Given this list of marker genes CLU, IL32, KRT81, LEF1, PANK4, EPB41, NPAS2, HTR2C, DUSP1, XPO7, HBE1, PSME3IP1, PRR16, METTL25B, SBNO1, TMEM101, PPME1, SH3TC2 (NCBI Gene Id 79628), CCL26, MPP1, STX2, MYO10, PRR29, WNT7A, CLDN4, TCIM, EML2, SOX4, IL1B, BCKDHB, ANAPC5, LINC01963, RABEP1, ASTN1, TCF7L2, DVL1, TCF4, SLC16A1, C4orf19, GCN1, IL6, TSPAN13, SAT1, RCAN2, CUX1, ZNF23, RUNX2, NR3C2, GAD1, NCOR1, LARP4B, CYP1B1, CD96, MATN2, RAD51C, SNAI1 (snail family transcriptional repressor 1), LIPA, INHBA, ITGA6, RBBP4, FBXO2, CCL2, ADGRF1, CALB2, SYT1, G0S2 (G0/G1 switch 2), FAXC, TENT5A, PDE10A, CYP2R1, ADPRM, EP400, FOXG1, ALDH6A1, H3-3B, ZCCHC8, SLCO1B3, DNAJC12, TERF2IP, MMP10, CCNE1, ANKRD6, GAA, RBL2, L3MBTL1, WDHD1, TNC, MFHAS1 (NCBI Gene Id 9258), CDK11A, SHROOM2, PTK7, GATA6, LAMC2, CDC42EP3, AREG, TGFB2, PCM1, ZMYND12, FAM174B, PLAT, PIR, FUCA1, SDHAF1, GNB1, EFHD1, THSD4, UTP25, NES, ZBTB33, CDS1, FHOD1, BDNF, CUL7, LAMB3, VAMP4, PLAU, ATMIN (NCBI Gene Id 23300), MCMBP, METTL13, CTSB, C8orf33, PXN, NR2F2 (nuclear receptor subfamily 2 group F member 2), RABIF, NPC1, CCDC69, LSS, SULT1C2, CLDN7, TGFB1, RFC5, SECTM1, DYNLT2B, KAT7, MXRA8, SPDEF, KLRC3, CRABP2, ITM2A, HTRA3, KCNN4, MTUS1, COIL, SSBP2, ADGRG6, PXDC1, DDX19A, BST2, S100A4, DYSF, STXBP6, ID4, LMNA, PRUNE1, AQP3, AMFR, TPK1, HCFC1R1, SENP6, PAAF1, MYO6, HNRNPUL1, MMP3, NKX2-5 (NCBI Gene Id 1482), SCG5, IL7R, PCCA, ADAM15 (ADAM metallopeptidase domain 15), CCDC25, TGFBI, ABL1, ATP8A1, PRSS2, SLC16A5, SATB1, ZNF26, UIMC1, SMARCA1, COQ5, OAS1, GUCY1B1 (NCBI Gene Id 2983), TFF1, MPP4, ENPP1, SPTLC3, CAPN6, CRADD, PTN, VPS4A, ADGRG1, PKIA, JUP, S100P, AGPAT4, OGFOD3 (2-oxoglutarate and iron dependent oxygenase domain containing 3), CDH2, LAGE3, CEBPD, GSN, IGF2R, LNX1, DST, TMEM8B, PSMB9, AK4, LSM2, TSR1, IFIT2, RGS4, MALL, LIMCH1, AP1G1, NOP16, SOCS2, TRPV2, DENND3, ACSF2, TRERF1, IL11, FHL1, KLF7, HDAC5 (histone deacetylase 5), ZG16B, SPINT2, GRWD1, ERBB3, CFB, AGR2, ADAMTS1 (NCBI Gene Id 9510), SYNJ2, INHBE, NET1 (NCBI Gene Id 10276), ARRB1, GSAP, TIGAR, LOX, GEMIN4, SENP3, H1-10, PI3, IGFBP4, AKAP1, HBG2 (hemoglobin subunit gamma 2), VSNL1, GEMIN2, KHDRBS3, RADX, BHLHE40, CILK1, LIF, SLC22A18, C1QL1, WIPF1, LMCD1, LRRC23, KAT6A, CASP1, ITGA10, PRSS1, RARG, CHML, SEC14L2, VPS37B, PAEP, HHLA2, MDC1, S100A2, TMT1A, CSTA, SMAD6, CPT1C, THAP11, COL6A2, AKR1C3, HMGN5, ALDH3A2, SMIM14, SDF4, TUBG2, POLR2C, NADK, SELENBP1, F11R, VWA8, TNS1, IGFBP7 (insulin like growth factor binding protein 7), TMEM158, LRRC47, OSMR, ANKLE2, ZNF395, PDE4B, PDSS2, APOLD1, NEDD9, SELENOP, DNAJB4, MYO18A, EFEMP1, H1-4, KLRC2, ZNF226, SHANK2, EEF1E1, PLD3, TACO1, SLC33A1, PAQR8, PSMC3IP, LDB2, EMP1, HADH, NDUFAF4, PC, POLR1C, PAPOLA, QSER1, TNFSF15, QPCT, LGMN, ABCD1, FUT8, KLF3, LRRC8B, KLHL20, ECPAS, HSD17B8, SLC38A10, GMFG, CDH11, CA12, TSC22D1, NRP1, PRKCA, MKRN1, PLAAT1, TOX2, CHST11, FICD, LZTFL1 (leucine zipper transcription factor like 1), ECH1, NUDCD3, C1orf174, CCN2, PMEPA1, ERBB2, HMGA1, RGCC, GBP2, PIGC, CDC5L, ST3GAL6, PNPO, PLLP, PTK6, HMGA2, SERPINE1, DDX41, FANCI, CCNG2, CXCL1, FGF5, TMEM132A, NSUN7, SPAG4, SQLE, NPY1R, LARP6, ITGB4, KRCC1, TNK1, ADGRE1, EGFR, MPZL2, PDK2, MAST4, PELI2, IFIT3, PHIP, FN1, FAM20C, TFPI2, FGF13, INSL4, NRG1, CYFIP2, FIRRM, ITGA3, here is a description of the gene set: Mechanisms underlying global changes in gene expression during tumour progression are poorly understood. SATB1 is a genome organizer that tethers multiple genomic loci and recruits chromatin-remodelling enzymes to regulate chromatin structure and gene expression. Here we show that SATB1 is expressed by aggressive breast cancer cells and its expression level has high prognostic significance (P < 0.0001), independent of lymph-node status. RNA-interference-mediated knockdown of SATB1 in highly aggressive (MDA-MB-231) cancer cells altered the expression of >genes, reversing tumorigenesis by restoring breast-like acinar polarity and inhibiting tumour growth and metastasis in vivo. Conversely, ectopic SATB1 expression in non-aggressive (SKBR3) cells led to gene expression patterns consistent with aggressive-tumour phenotypes, acquiring metastatic activity in vivo. SATB1 delineates specific epigenetic modifications at target gene loci, directly upregulating metastasis-associated genes while downregulating tumour-suppressor genes. SATB1 reprogrammes chromatin organization and the transcription profiles of breast tumours to promote growth and metastasis; this is a new mechanism of tumour progression. Human Gene Set: HAN_SATB1_TARGETS_DN studied in species Homo sapiens from publication Han HJ, Russo J, Kohwi Y, Kohwi-Shigematsu T (PMID 18337816) Genes down-regulated in MDA-MB-231 cells (breast cancer) after knockdown of SATB1 by RNAi.